The following is a description of a gene set: Human Gene Set: GOBP_NEUROTRANSMITTER_REUPTAKE The directed movement of neurotransmitter molecules from the extrasynaptic space into the presynaptic cytosol. species: Homo sapiens, and this is the list of marker genes: SLC6A1, SNCA, SLC22A2, SLC6A3, ITGB3, DRD2, SLC18A1, DRD3, CLN8, SLC6A12, PARK7, SLC6A4, SLC18B1, NOS1, SLC18A2, SLC6A11, DRD4, SLC1A2, PER2, SLC18A3 (NCBI Gene Id 6572), SLC6A2 (solute carrier family 6 member 2), GDNF, SLC17A8, GPM6B, DRD1, SLC22A1, SLC6A13, SLC29A4, KCNJ10, SLC22A3, PRKN, ITGB1, TOR1A, RAB3B, ATP1A2 (NCBI Gene Id 93186)